Given this list of marker genes NEK6, PLK1, CCNB2, NEK9, CCNB1, CDK1, NEK7, here is a description of the gene set: studied in species Homo sapiens part of: Nuclear Envelope Breakdown Reactome Pathway: Activation of NIMA Kinases NEK9, NEK6, NEK7 NEK6 and NEK7 are activated during mitosis by another NIMA family kinase, NEK9, which is activated by CDK1- and PLK1-mediated phosphorylation.